The following is a description of a gene set: A lesion located beneath a fingernail or toenail. species: Homo sapiens Abnormal subungual morphology Human Gene Set: HP_ABNORMAL_SUBUNGUAL_MORPHOLOGY, and this is the list of marker genes: TSC1, ATP2A2, KRT17, JUP, TSC2, KRT14, CARD14, COL7A1, MBTPS2, IFNG, KDF1, TRPV3